The following is a description of a gene set: species: Homo sapiens Any process that modulates the frequency, rate or extent of lymphocyte chemotaxis. Human Gene Set: GOBP_REGULATION_OF_LYMPHOCYTE_CHEMOTAXIS, and this is the list of marker genes: ADAM17, CCL7, CXCL10, CCL2, NEDD9, PADI2, XCL1, ADAM10, KLRC4-KLRK1, STK39, TNFSF14, CCL4, OXSR1, CCR2, TMEM102, WNT5A, S100A7, KLRK1, CXCL13, CCL3, PTK2B, WNK1, CCL5, SLC8B1, CCL21